The following is a description of a gene set: species: Homo sapiens Gene expression profiles were examined in 33 adult patients with T-cell acute lymphocytic leukemia (T-ALL). Nonspecific filtering criteria identified genes differentially expressed in the leukemic cells. Hierarchical clustering of samples identified 2 groups that reflected the degree of T-cell differentiation but was not associated with clinical outcome. Comparison between refractory patients and those who responded to induction chemotherapy identified a single gene, interleukin 8 (IL-8), that was highly expressed in refractory T-ALL cells and a set of genes that was highly expressed in leukemic cells from patients who achieved complete remission. We next identified genes that were differentially expressed in T-ALL cells from patients who either had a relapse or remained in continuous complete remission. A model based on the expression of 3 of these genes was predictive of duration of remission. The 3-gene model was validated on a further set of T-ALL samples from 18 additional patients treated on the same clinical protocol. This study demonstrates that gene expression profiling can identify a limited number of genes that are predictive of response to induction therapy and remission duration in adult patients with T-ALL. Genes whose expression predicted relapse in less than 2 years after chemotherapy for adult patients with T-ALL (T cell lymphoblastic leukemia). from publication Chiaretti S, Li X, Gentleman R, Vitale A, Vignetti M, Mandelli F, Ritz J, Foa R (PMID 14684422) Human Gene Set: CHIARETTI_T_ALL_RELAPSE_PROGNOSIS, and this is the list of marker genes: TTK, SEC31B, CENPF, CD8A, AHNAK, CD2, CDC7, NDC80, MEF2A, CAT, HNRNPH1, MYC, DEK, USP1, BUB1B, RCBTB2 (RCC1 and BTB domain containing protein 2), MELK, IRAG2, H2AX